Given this list of marker genes CACNA1D, STIL, SIX3, DLL1, NODAL, GALC, SHH, GSN, CDON, GLI2, STAG2, PLCH1, FGF8, GAS1, TGIF1, PSAP, ZIC2, PTCH1, PHOX2B, CRIPTO, MADD, SMC1A, FGFR1, FOXH1, DISP1, here is a description of the gene set: Human Gene Set: HP_ABNORMAL_HEART_RATE_VARIABILITY Any abnormality in the variability of the time interval between successive heartbeats. species: Homo sapiens Abnormal heart rate variability